The following is a description of a gene set: Human Gene Set: HP_LIMB_GIRDLE_MUSCLE_ATROPHY Limb-girdle muscle atrophy Muscular atrophy affecting the muscles of the limb girdle. studied in species Homo sapiens, and this is the list of marker genes: GYG1, ACTB, MORC2, UNC45B, CRPPA, POMT2, SYNE1, POMT1, LMNA, FHL1, DES, FRG1, HNRNPDL, CAPN3, TRAPPC11 (NCBI Gene Id 60684), DAG1, SMN1, TRPV4, TMEM43, FKTN (NCBI Gene Id 2218), COL6A1, DPM3, ANO5, SYNE2, VCP, ACTA1, FKRP, TRIM32, SGCB, TPM3, POGLUT1, DGUOK, HNRNPA1, SGCA, SMN2, MYH7, EMD, GNE